Given this list of marker genes TTC7A, IL18BP, ITCH, DCLRE1C, FOXD3, POLG, PTEN, CDKN1B, CLCNKB (chloride voltage-gated channel Kb), SEC23B, PLCG2, PI4KA, MYT1L, CTLA4, TBX2 (NCBI Gene Id 6909), ADA2, C1S, SLC12A3, here is a description of the gene set: Human Gene Set: HP_HASHIMOTO_THYROIDITIS A chronic, autoimmune type of thyroiditis associated with hypothyroidism. studied in species Homo sapiens Hashimoto thyroiditis